The following is a description of a gene set: studied in species Homo sapiens Catalysis of the reaction: lactate + NAD+ = H+ + NADH + pyruvate. Human Gene Set: GOMF_LACTATE_DEHYDROGENASE_ACTIVITY, and this is the list of marker genes: MLDHR, LDHAL6B, LDHA, LDHAL6A, LDHC, LDHB, LDHD